The following is a description of a gene set: species: Homo sapiens Human Gene Set: GSE17301_ACD3_ACD28_VS_ACD3_ACD28_AND_IFNA2_STIM_CD8_TCELL_DN Genes down-regulated in CD8 T cells activated by anti-CD3 and anti-CD28 versus those stimulated by IFNA2. from publication Hervas-Stubbs S, Riezu-Boj JI, Gonzalez I, Mancheño U, Dubrot J, Azpilicueta A, Gabari I, Palazon A, Aranguren A, Ruiz J, Prieto J, Larrea E, Melero I (PMID 21108462) IFN alpha mediated gene expression pattern. The effect of IFN alpha on human CD8 T cells responding to antigen (signal 1) and costimulatory signals (signal 2) provided by beads coated with anti-CD3 and anti-CD28 mAbs. This analysis examined the effects of IFN alpha on human CD8 T cells responding to antigen (signal 1) and costimulatory signals (signal 2) provided by beads coated with anti-CD3 and anti-CD28 mAbs. Magnetically sorted untouched CD8+CD45R0- T cells from three different donors were unstimulated or stimulated with IFNa2b or with anti-CD3/CD28 Beads alone or along with IFNa2b or IFNa5 for 48 hours. Individual mRNA samples were analyzed using HG-U133A 2.0 array gene chips., and this is the list of marker genes: AKAP10, DENND4A, PLN (phospholamban), APPBP2, DCAF1, ZNF200, PAPOLG, CHMP7, RIGI, IPCEF1, DIAPH1, FBXL4, HMOX2, RNF144A, RIPOR2, CLCC1, PCK2, FOXO1, PER2, ANKRD55, ZNF189, CBFA2T2, CDK17, P4HTM, RNF111, CTSL, CTSB, HOXB2, CLIP1, CREBBP, ADAM23, CD226, MOCS2, RGS19, SLC18A2, DDX60, CNOT4, NIP7, ETHE1, CFP, OSBP, FHIP2B, COQ10B, NME3, PCYOX1L, NDRG3, XYLT1, ZNF274, VWA8, HGSNAT, KLF10, FLT3LG, GAPVD1, NPAT, LITAF, MTMR14, GIN1, SPINK2, SERINC5, TTC27, IFIH1, CASP4, TMPRSS3, KDSR, CPD, CCPG1, CYTH1, IPPK, SPRY2, TES, TPM2, TRIM32, RIOX2, BAG3, ZFAND3, TMEM183A, TRAF3, SUN2, TTLL1, RALGAPA1, LIPT1, ZNF140, LRFN3 (leucine rich repeat and fibronectin type III domain containing 3), LRBA, GNS, HPGD, DIPK1A, AVL9, TIMM10B, ZFYVE16, LY96, ABCC4, TRAM2, SLC31A1, PCTP, CRYZ, CORO1B, EXOC2, SLC7A6, LRRC8B, GPC3, IFIT1, OPTN, MGAT4A, ARHGAP17, CHD7, LIN7C, GIMAP5, ZC3HAV1, PRKD3, CHD3, FUT8, RUBCN, SGPL1, PDLIM5, CCDC88C, DZIP3, TDRD7, ATF7IP2, NDST3, TTC17, ZNF354A, PRDM4, ZSCAN16, IFNAR1, ARID5A, SMAD7, TAOK3, PITPNC1, RNF44, C21orf91, BAK1, ENPP2, FBXL5, NEU1, BTN2A1, ARMCX2, BTN3A3, RSAD2, HIVEP1, SGPP1, GIMAP4, SLC30A1, EFNA4, PTP4A1, RYK, CTBS, PDIA5, NAA60, ENTR1, JRKL, GALNT11, SENP7, GPR183, UBL3, DACH1, BCL2A1, POMGNT1, INPP4B, QPCT (NCBI Gene Id 25797), RAB33A, OGG1, TLR1, MYLIP, EDEM2 (NCBI Gene Id 96814), RSU1, LAPTM4B, C1GALT1, ABCB1, BAG4, ZNF573, ZCCHC14, ACVR1, RHOF, HTR2B, RAB3GAP1, PLEKHB1, CSGALNACT1, ATXN1, NELL2, IL6R, S1PR1, HIBCH, TESPA1, SIPA1 (signal-induced proliferation-associated 1), TMEM268, PUS3, CLN5, MAGT1, NCF1C, NR4A2 (NCBI Gene Id 4929), PDGFA, WDR33, GBP1, YJU2, N4BP2L1, USP18, GPRASP1, DACT1, GADD45B